Given this list of marker genes HSPA5, DNAJB6, BAG1, RLN1, NUP214, HSPA4L, SIRT1, DEDD2, NUP153, NUP188, NUP42, HIKESHI, BAG3, HSPA2, MRPL18, HSPA6, SEC13, NDC1, HSPB1 (heat shock protein family B (small) member 1), HSPA1B, MAPK3, BAG5, AAAS, RANBP2, HSPA1A, NUP107, ST13, SERPINH1, HSPH1, NUP62, NUP210, POM121C, YWHAE, NUP205 (nucleoporin 205), HSPA12B, TNFRSF21, HSPA12A, ATM, MAPKAPK2, DNAJC2, UBB, GML, CRYBA4, NUP50, HSPA13, HSPA4, NUP160, RAE1, FKBP4 (FKBP prolyl isomerase 4), NUP35, BAG4, HSF1, NUP43, NUP85, MAPK1, BAG2, ATR, DNAJB1, HSPA8, RPA2, POM121, NUP98, HSPA9, NUP133, NUP155, DNAJC7, HSPA14, NUP58, NUP88, RPA3 (replication protein A3), NUP37, NUP54, CCAR2, HSPB2 (heat shock protein family B (small) member 2), TPR, GSK3B, HSPA1L, RPS19BP1, COL4A6, RPA1, NUP93, SEH1L, here is a description of the gene set: Regulation of HSF1-mediated heat shock response Human Gene Set: REACTOME_REGULATION_OF_HSF1_MEDIATED_HEAT_SHOCK_RESPONSE species: Homo sapiens